Given this list of marker genes Stoml2, Pard6a, Mospd3, Ergic1, 4930519F09Rik, Dgkeos, Sp140l2, Mapk3, Ppp4c, Or7e174, Rbm3, Gm10764, Gm15159, mt-Tv, Rpl27, Calr3, Mybpc1 (NCBI Gene Id 77491), Mir6372, Gm15350, Rad18, Ccdc183, Crlf1, D830013O20Rik, Gm40330, Rian, Susd1, Rpl31-ps8, Cep85, Abcg2, Mpo, Gm20239, Polr1b (NCBI Gene Id 320298), Gfra4, Gm7485, Gm29926, Ltbr, Tceanc2, Mir7681, Med9, Gm4929, Ccdc142os, Washc3, Ugt2a2, Sgca, Iqgap3, Lrrc45, 4933427E13Rik (NCBI Gene Id 71234), Cdh23, Mus81, Ighv1-67, Gapvd1, Gm12842, Hfm1, Mir342, Ccdc177, Ecrg4, Vmn2r-ps18, Car4, Hipk4, Zfp513, Tex10, Gm8357, C030034I22Rik, Dglucy, Mgam, Gm23336, Robo2, Stil, Gm7984, Vmn1r-ps149, Gm7343, Prom1, Cfap68, Ankfy1, Foxm1, Zfp998, Luc7l, mt-Nd4l, Bud31 (BUD31 homolog), Or2m13, Rpusd4, Pcbp3, Kremen1, Nmrk1, V1ra8, Alg9, Htra2, Agbl5, Hsd11b1, Bhmt-ps1, Amz2, Cox15, Gm21978 (NCBI Gene Id 622846), mt-Tt, Ccdc24, Gm20072, Ccdc9, Iba57, Fam120c, Tprkb, Paxip1, Larp1b, 4930539J05Rik, Crtc3, Cxxc1, Or5t17, Psmd11, Gm8531, Mrgpra6, Hjurp, Lrrc8d (leucine rich repeat containing 8D), Slc6a11, Vps37d, Bcl2l12 (NCBI Gene Id 75736), Mier2, Actr3, Fam171a2, Taar5, Cbs, Harbi1, Ap1m1, Trpm8, Hycc2, Arhgef19, Gpr15lg, 1700015C17Rik, Hsd17b8, Pkd1l1, Gm6877, Card6, Stmp1, Wdr1, Dhx9, 4932414J04Rik, Or14j7, Astn1, Gm8425, Cypt2, Krt90, Sema4d, Gm26408, Mir7036b, Entrep3, Gm5600, Pfdn4, Elobl, Rbbp5, Cep70, Gm26357, mt-Nd6, Or2av9, Kpnb1, Gucy1a1, Kcnh6, Cyp4b1, Sirt7, Kcnj15, Gm12354, Rbms1, Sft2d1, Gm16165, A230006K03Rik, Slc25a45, 1700030K09Rik, Por, D030068K23Rik, Mipol1, Maco1, Txnrd2 (NCBI Gene Id 26462), mt-Th, Lipn, Zfp988, Ifit1bl1, Usp16, Hspa4, Serpinb5, Uevld, Ppp2r2d, Gm33609, Gm19585 (NCBI Gene Id 100503190), Col24a1, Ndrg3, H2-Aa, Fnbp1, Lamtor1, Nek8, Or5ar1, Coro1c, Ica1l, Gm24728, Pdgfd, krtap20-23, Slc15a4, Igha, Gm15926, Poc5, Egr3, Mindy1, Polr1e, Gm12220, Tfg, Gm8581, Gm10298, Zdhhc12, Nif3l1, Lyar, Mast4, Stk11, Arhgap1 (Rho GTPase activating protein 1), mt-Ts2 (NCBI Gene Id 17743), Tmem178b, Gm7693, mt-Tg, Cdc42bpa, Mapk8ip1, Ghdc, Naaa, Dguok, Cfap144, Zc3h7a, Gm4596, Rnf13, Mlip, Gm10644, mt-Nd3, Gm7205, Grcc10, Thoc6, Igkv14-126 (immunoglobulin kappa variable 14-126), C1qbp, Wwtr1, Or10al6, Gm18529, Supt6, Slc35a1, Mir1b, Arhgef5, Rpl30 (NCBI Gene Id 19946), Gm25521, Rb1cc1, Airim, Rsbn1l, Ddx51, Alkbh3, Mir1945, Shoc2, Ifitm7, Galns, Gm10804, Mycbp2, Topbp1, mt-Ta, Mir6908, Cutc, Mrpl18, Or4f7, Map3k14, Gpx8, Sirpb1b, Lmbr1, Or5d45, Cd86, Mapkapk5 (NCBI Gene Id 17165), 4930579O11Rik, Rngtt, Pih1d1, Egr4, Usp8, Myh7b, Or52n3, Mbd5, Vmn1r206, Cacna1f, Ggt1, 2510017J16Rik, Phrf1, Gm16096, Irf5, Gm4894, Gm11977, Oasl1, Kat6b, Ccdc86, mt-Tp, Scrt1, Nlgn3, Chd1l, Ighv1-45, Cops8, Lpl, Gm25979, Actrt1, Gar1, Defb8, 1700030C14Rik, Mbnl1 (muscleblind like splicing regulator 1), Rpl36a-ps1, Zbtb17, Txndc9, Gm28802, Aurka, Pramel24, Orc4, Snord37, Aftph, Rtel1, Ighv3-8, Gspt1, Srd5a1, Gm5420, Snora5c, Or5k3, Pkdcc, Cib4 (calcium and integrin binding family member 4), Xpo6 (exportin 6), Ighg2c, Xpnpep1, Rasl11a, Nrg3os, Glcci1 (NCBI Gene Id 76466), Bhlhe23, Crybg3, Gm14455, Wdr17, Tdrkh, Gm26881, Hepacam2 (HEPACAM family member 2), Etd, Nat8, Enox1, Itgad, Ston2, Gm8930, Vmn2r63, Ppip5k2, Ighv2-8, Gm6187, Gm5547, Fndc1, Slc11a1, Strit1, Nr4a1, Xrcc6, Gc, mt-Ti, Cramp1, Gm14769, Sez6, BC006965 (NCBI Gene Id 675114), Tns1, Tada3, Tmem39a, Asap3, Trrap, Gm18356, Tmem59, Amtn, Zp2, Usp46, Lrrk2, D630023O14Rik, Gm20319, Klf3, A730081D07Rik, Exoc5, Tbc1d1, Bet1l (NCBI Gene Id 80411), Sorbs2, Lats2, Defb1, Kalrn (NCBI Gene Id 72378), Gm3765, Rbpj, Crocc, mt-Cytb, Dgkz, Or6b2, Scrib, Myo1b, Gm23839, Smarce1, Pwwp3b, Thrap3, Gm12819, Gm15732, Morc3, Gm18829, Gm25915, Hmgxb4, Gm8515, Gm5702, Akt1, 4930401G09Rik, mt-Co1, Cystm1, Aadacl4fm1, Gm5278, Gm22042, Tha1 (NCBI Gene Id 71776), Vmn1r-ps99 (NCBI Gene Id 100417065), I830134H01Rik, mt-Td, Gm12263, Mroh2a, Kit, 1700021A07Rik, Chp1, Gm25757, Or1d2, Rgs12 (NCBI Gene Id 77052), Lrrc1, Tmem185a, Scfd2, Defb45, Chd8, Map2, Ambn, A530072M11Rik (RIKEN cDNA gene A530072M11), Irf3, Mad2l1bp, mt-Te, Cstf1, Bmerb1, B3glct, Asf1b, Mir1a-2, Mul1, Col17a1, Psma5, Zfp27 (zinc finger protein 27), Meltf, Xrcc3, Deup1, Pdia3, Adgrl4, Gm8584, Fnip2, Rlim, Gm7824, Surf6, Prune1, Ssbp4, Gm28980, Krtap13-21, Gm15160, Mrtfa, Gm34023, Jph4, Or56a5, Vps50, Ct45a, Rabgap1l, Gm7820 (predicted gene 7820), Hmgn2-ps1, Nme8, 4930596I21Rik, Pramel12, Or14o1-ps1, Mir7230, Rab39, AA986860, Inpp5b, Tent5c, Ccny, Lrp8, Gm13260, Or5p1, Krtap4-24, Or8k21, Sf3b1, Smarcd2, Gucy2e, Defb38 (defensin beta 38), Ak9, Piwil4, Cyb5r1, Plekhg5, 1700034H15Rik, 2810428J06Rik, Pcsk6, Acad12, Gm4956, Itpripl2, Mtfr1, Dlgap5, Wdr47, Mtus1, Gm14489, Vmn2r104, Mtmr2, mt-Nd2, mt-Nd5, Gm22863, Rnf207, Gprc5d, Spata31e2, Tcp1, S100pbp, Ints15, Dnajc13 (DnaJ heat shock protein family (Hsp40) member C13), Trp53rkb, Fau-ps2, Hint1, Acot1, Or2t43, Gm3604, Lrrfip1, 1700083H02Rik, Pttg1ip, Nagk, Mrpl53, Hlcs, Gm36934, Rbm34 (RNA binding motif protein 34), Gm18341, Gpr107, mt-Ty (mitochondrially encoded tRNA tyrosine), Mir138-1, D030047H15Rik, Rhpn1, Fnbp4, P4ha2, Gm23039, Mir92b, Tcp11l2, Uap1, Nfs1, mt-Tq, Igkv12-40, Slc25a40, Dync2h1, Gm13882, Ltf, Gm53055, Gzmd, Tgoln1, Dusp5, AU041133, Iscu, Lypd10, Tas2r140, Gm15071, Gpat3, Pcnx3, Gm23655 (predicted gene, 23655), Actb (actin, beta), Tas1r1, Tnfsf10, Crb1, Pomt1, Snw1, Ift140, Mapk7, Vamp2, Myoc (myocilin), Pigm, Fzd5, Tbc1d31, Ccl17, Gm5388, Pepd, Mir7015, Cd101, Or5w12, Or8c11, Gm11399, Caprin1, Mfap1b, Gm12924, Slc4a8, Or10al3, Slc4a5, BC018473, Lxn (latexin), Per1, Gm10059, Dsn1 (NCBI Gene Id 99407), Il24, Mrpl22, Fam227a, Gm3940, Abhd10, Tbpl1, Or8g18, Gm11725, mt-Tl2, Slc25a19, Gm14292, Qtrt2, Sertad2, Cct8 (chaperonin containing TCP1 subunit 8), Fndc8, Agr2, Septin6, Itgb1, Otud6b, Mcoln1, Mir101a, Gnb2, Epn1, Ppil6, Gm4744, Dkc1, Ints3, Coq8b, Phkb, Gal3st1, Adck2, Nxn, Mideas, Ric8a, Rnf213, Blvrb, mt-Nd4, B430010I23Rik, Arpc3, Gm8848, Fbf1, 1700013M08Rik, Ezh2 (enhancer of zeste 2 polycomb repressive complex 2 subunit), Gm12470, Galnt1, Cep55, Kctd5, 2810039B14Rik, Phf21a, Egr1, Dctn1, Mtx2, Add3, A730035I17Rik, Or5w8, Gm29492 (NCBI Gene Id 626181), Trappc2l, Gm2065, Fam117a, Dctn5, Gm24061, Gm25541, Ighv14-3, Dlx2, Iffo1, Gm14661, Usp12, Cog8, Samsn1, Mfn1, Gm14520, Gm13421, Or4p18, Gm28167, 1700040D17Rik, Pcdhgb2, Gm15983, Vmn1r239-ps, Gm19774, Tnfaip8, Smc1a, Ptpn12, Gm24071, 1700061I17Rik, Bst2, Orc1, Vmn1r46, Prx, Pgk2, Gpatch3, Ccdc39, Vsig10l, Gm13316, Ighv5-13, Ap4e1, Or5b117, Tmem63b, Tmem198b, 4930426D05Rik, Mettl5, Ccdc30, Rpl31-ps9, Pnpt1, 4930506C21Rik, Tpmt, 5031439G07Rik, Gm6236, Kel, Kdm1b, Gm9320, Fos, Abca1 (NCBI Gene Id 11303), Kcnn1, B430212C06Rik, mt-Tr, Gm10466, Nlrp3, Gm13180, Gm26670, Amn1, Gm25604, Zfp719, Entrep2, Cped1, Prkci, Ube2d3, Ints4, Brinp1, Gm24162, Calb1, Gm15387, Mir6381, Sycp2, Spata7, Igkv6-32 (NCBI Gene Id 791263), Gm6313, Gm2427, Eef1a2, Or51f5, Kmt2a, Cdk14, Rxfp1, Lce1i, Ostf1, 4933405D12Rik, Syt5, Ssxa1, Amer1, Trhr2, Gm9034, Ripk2, Ighv14-4, Itfg2, Hoxb3os, Mtx1, Fbxw9, Zeb1 (NCBI Gene Id 73165, zinc finger E-box binding homeobox 1), Dis3, Gm13546, mt-Rnr2, Arhgef2, Cfap36, Slc29a1, Or7e178, Parn, Drp2, Iqce, Lamc2, Nol9, Gm9979, Wipi1, Met, Trappc2b, Lhx1, Gpbp1, Myo10, Cspg4b, Gm9767, Cd200r3, Krtap13, Ang4, Gm8919, Slc43a2 (NCBI Gene Id 319797), Git2, Gm5310, Mir1934, Carm1, Lyl1, Anapc2, Ppp1r18os, Slamf7, Nsun2, Or4x11, Or6c207, Pds5b, Emid1 (EMI domain containing 1), Ache (NCBI Gene Id 11423), Grm8, Ttn, Crisp2, Zfp787, Zfp839, Fam118a, Ppp2r5a, Map4k2, Lce6a, Igsf5, Krtap19-3, mt-Tl1, Wnk1, Ylpm1, Sdr16c6, Gm6985, Gm5921, Gm21221 (NCBI Gene Id 100861794), Ank3, Tlcd1, Cnot9, Pxn, E230020A03Rik, Or5k14, Ssu72, Slc35a4, Ubash3a, 3110070M22Rik, Glis1, Gm8806, Pwwp2a, Abca2, Dock10, Scmh1, Dpp7 (dipeptidylpeptidase 7), Slc35c2, Nup88, Cpeb1, Cmas, Micall2 (MICAL-like 2), Dmbx1, Gm9211, Or6c8b, Gm14270, Grm1, Uqcc1, Haus6, Esp34, Kcnk3, Gm6051, Tssk5, Abhd17a, Eif2s1, Aldh16a1, Ythdf1, Pcdh1, Dpysl3, Fnd3c2, Gm18327, Rela, Or8g52, Calcoco1, Fhl2, Ube2f, Ctsw, 1700057H15Rik, Acsf2, Or7e168, Magea4, Tex55 (testis expressed 55), Arhgap11a, Pip5k1bos, Agrn, Kif17, Trip4, Cntn2, Gm11606, Gm22978, Mcm10, Renbp, Cic, Afdn (afadin, adherens junction formation factor), Cby1, Lap3, Amn, Gm18304, Ahctf1, Fam234a (NCBI Gene Id 215528), Gm24313, Tapt1, Gm11704, Nphp4, Wdr24 (NCBI Gene Id 268933), Kirrel3, Cdk10, Rab39b, Ldb1, Or4f53, Nip7, Cyp4a12a, Gm22795, Plekhm2, Zc3h15, Gm40319, Gm9104, Il36rn, Gm15631, Ube2j2 (NCBI Gene Id 73831), Sart3, Dnase1, Kcnmb4, Lamb3, Prickle2, Lsm7, Angptl7, 2810404F17Rik, Pcdh11x, Itga9, Il20rb, Amfr, Daglb, Gm12579, Vmn2r-ps85, Pcgf1, Trmt1, Gm37450, Sec13, Spon2, Slit2, Cds1, Sec16b (SEC16 homolog B, endoplasmic reticulum export factor), Nelfa, Pak1ip1, Fmo4, Slc2a12, Dntt, A930038B10Rik, Atosb, Gm14208, Rnd2, Pafah1b3, 6030442K20Rik, Alyref2, Gm9273 (predicted gene 9273), Gm15723 (NCBI Gene Id 102633245, predicted gene 15723), Gm7583, Jakmip2, Sirt4, C8g, Lepr, Kifap3, Ubqln1, Arap2, Frmd5 (FERM domain containing 5), R3hdm1, Eif5b, Ssb, Brca1, Ap5m1, Gm25832, Aup1, Tll2, Tpsb2 (tryptase beta 2), Camk2d, Vmn2r91, Otud4, Gm13472, Gm11400, Ribc1, Plekhg2, Mir2136, Pknox2, Gm5619, 6430548M08Rik, Gm13281, Ighv6-4, Vmn1r202, Zfp408, Gm6621, Sbf1, 5430434I15Rik, Gm12813, AI849053, Ear14 (eosinophil-associated, ribonuclease A family, member 14), Tbx3, Gpcpd1, Ildr1, Or1f12, Or4f47, Gm13416, Rasgrp2, Spinkl, Trim7, Mtif2, Gm11407, Gm16418, Bche, Pwwp4-ps, Vps16, Lin37, Egr2, Rtf2, E330013P04Rik, Gm23698, Hmgxb3, Myo5a, Ugt1a1, Anapc5, Gm3355 (predicted gene 3355), Bsg, D7Ertd443e, Dlgap2, Leng8, Echdc3, Nlk, 9330175E14Rik, Or6c76, Npepps, Eif2d, Gm6451, Tex56, Cntn4, Tbrg4, Vil1, Cap1, Gm16459, Rcor3, Grin2a, Ighv12-3 (NCBI Gene Id 435321), Fam114a1, Ubap1l, Nkain4 (Na+/K+ transporting ATPase interacting 4), Rhox2h, mt-Tc (NCBI Gene Id 17727), Gm10923, Ublcp1, Fanci, Pomp (proteasome maturation protein), Ly6e, Pitpnm2os1, Gm20652, Edn3, Arhgef17, Acad10, Mir124a-1hg, Gm25999, Speer4c2, Klhl20, Stab2, Mast2, Ppil3, Gm21362, Nlrp4c, Ift46, Copa, Pramel6, Gm2950, Trpc4ap, Jam2, Nme1, Or52f1-ps1, Egfem1, Tmem164, Hipk3, Rasa1, Tas2r121, Arhgef7, Sf3a2, Ssbp3, Gm16061, Cfap410, Ei24, Sult2a-ps2, Gm7285, Or1j20, Nudt12, Gm24185, 1700041I07Rik, Tut7 (NCBI Gene Id 214564), Or6e1, B3galt9, Gm19461, Aldh1l2, Dolk, Camta2, Gm13162, Esrrg, mt-Tw, Ep400, Ccdc88a, Bcl2a1b, Ghrhr, Gm37915, Sned1, Chrm3, mt-Nd1, Lsamp, Gm14044, Ccdc150, Or5d39, Ap1ar, Vmn2r-ps125, Fbxo46, Csnk1g2 (casein kinase 1, gamma 2), Add1, Exd1, Fkbpl, Kmt2e, Arc (activity regulated cytoskeletal-associated protein), Tdp1, Dph3, mt-Co2, Snrnp200, Tns3, B130034C11Rik, Sptbn4, Gm22283, Tyw5, Zfp146, Ighv1-26, Chst10, Zfpm1, Pate13, Pcdhga1, Aptx, Sec24c, Mast3, Zfp981, Bdp1, Gm22158, Platr11, Arpc4, G630018N14Rik, Atp6v1d, Gm15564, Nelfb, Cirbp, Rnu7, H4c2, Cstf2, Mir6936, Eddm13, 4930568A13Rik, Iqch, Tcaf3, Gm23389, Gtf2ird2, Nmrk2, Pfkfb3, Tmem267, Trim2, Nphp3, Or9a2, Fibp, Vav2, Gm14880, Prpf38a, 9130227L01Rik, Nolc1, Esp18, Ark2c, Pate2, Or5p58, Ankrd13d, Scyl3, Epha7, Clec4n, Efcab6, Med9os, C130026L21Rik, Tmem209, Foxp2, Bloc1s1, Gm9274, Ndrg1, Gm26747, Iffo2, Gtpbp2, Duxf1, Ube2m, Gm30292, Vps26c, Khk, Uap1l1, Gm25561, Suds3, Coil, Mir148b, Gm29387, mt-Tm, Rpl29-ps5, Zfp217, Gls2, Inpp5e, Gnl3l, Gatd3a, Sugp2, Or11g24, Gm6981, Mark2, Alas1, Gm25724, Gm26085, Trmt6, Gm20620, Pthlh, Cog1, Adh6a, Epb41, 1700017N19Rik, Hoga1, Gm13415, Gm13578, Atg13 (autophagy related 13), Zcchc17, Gm22297, Gm19938, Zfp429, Tpm1, Axdnd1, Or4f14, 2900022M07Rik, Dock11, Lhfpl6, Itpkc, Gm10240, Arhgap15, Fgd1, 2700099C18Rik, Gm22284, Sfi1, Acsl3, Hyal5, B4galt3, Rpgrip1, Rab37, Mroh5, Slc45a4, Cecr2, Uqcc4, Gm20629, Srms, Gm25699, Slu7, Tmtc2, Msantd1, Diras2, Defb47 (NCBI Gene Id 654465), Rhbdf1, Pus10, Ovgp1, Rars1, Rpl26, Gm16288, Scamp1, Homer1, Ankra2, Kyat1, Sh3d19, Gm6088, Hapln4, Gm18717, Mir6236, Dok7, Cers6, Crispld2, Ddx1, Grin2b, Smg5, Scai, Ttc29, Gm13920, A1bg, Gm24151, 1810037I17Rik, Saraf, Or1e27-ps1, Mettl5os, Hspg2, Patj (PATJ, crumbs cell polarity complex component), mt-Tn, Tigd3, 1810024B03Rik, Or1e21, Serpinb9c, Cnga3, 4930555F03Rik, Ssbp1, Speer4cos, Txndc11, Mir140, Fam184a, Mir7668, Stradb, Hpcal4, Asph, Gm15389 (NCBI Gene Id 102635334), Sec31b (SEC31 homolog B, COPII coat complex component), here is a description of the gene set: Mouse Gene Set: ELK1_TARGET_GENES Genes containing one or more binding sites for (Elk1) in their promoter regions (TSS -1000,+100 bp) as identified by GTRD version 20.06 ChIP-seq harmonization. from publication Yevshin I, Sharipov R, Kolmykov S, Kondrakhin Y, Kolpakov F (PMID 30445619) studied in species Mus musculus